Given this list of marker genes CPLX2, RASGRF2, RITA1, DCX, E2F6, ERAP1, RBPMS, ZFP82, RANGRF, HTR2C, TNFRSF21, ITPK1, CYP7A1, GNS, UCHL1 (NCBI Gene Id 7345), HSBP1, RGS10, SPAST, ARID4B, LRATD2, SMOX, BAZ2A, INO80, XKR6, B3GNT2, KDM5B, TIMP4, RABL2B, MPHOSPH9, CDC14A, MAOA, MYRIP, SRFBP1, FRMD5, GLO1, BTBD6, ZNF691, GATA2, SNX3, OPCML, PPP4R3A, SPMIP4, PICALM, RABL2A, JARID2, CDK5RAP2, HEYL, CPNE8, DCANP1, RRM2B, SUPT3H, ATP1A2, ZNF680, SGO2, CPA6, EPHA4, TICRR, FAM20B, CENPO, PTPMT1, SLN, APBB1, SPMAP1, SUMO2, DCTN4, DYNAP, CYP7B1, LIN7A, DDX52, UBE2D2, RSPO3, TNFSF4, JPH2, SLCO3A1, CEP170, FUT10, SOX10, CCL18, VDAC1, ANGPTL2, AAK1, SMIM9, TBX15, NSD3, BPHL (biphenyl hydrolase like), AUTS2, MANBAL, here is a description of the gene set: Human Gene Set: MIR6864_5P from publication Chen Y, Wang X (PMID 31504780) Genes predicted to be targets of miRBase v22 microRNA hsa-miR-6864-5p in miRDB v6.0 with MirTarget v4 prediction scores > 80 (high confidence targets). species: Homo sapiens